The following is a description of a gene set: A kind of anemia in which the volume of the red blood cells is reduced. Microcytic anemia Human Gene Set: HP_MICROCYTIC_ANEMIA studied in species Homo sapiens, and this is the list of marker genes: WAS (WASP actin nucleation promoting factor), PSTPIP1, PIK3CA, HBG1, HBG2, TEK (TEK receptor tyrosine kinase), SLC37A4, IREB2, IL6ST, BCL11A, ATRX, C2orf69, SLC25A10, SLC35C1, SLC25A21, AGGF1, CARD10, TAFAZZIN, LPIN2, SLC29A3, CAT, HBA2 (NCBI Gene Id 3040), HBA1, FECH, KARS1, ALAS2, TRNT1, SUCLA2, HBB, PSMB8, FDX2, TMPRSS6, CP (NCBI Gene Id 1356), TKFC, PUS1, IRX5, WIPF1, RIPK1, OSTM1, SHPK (sedoheptulokinase), KLF1, FARSA, TBK1, DNAJC19, SMPD1, SRD5A3 (NCBI Gene Id 79644, steroid 5 alpha-reductase 3), HBD, HSCB, ABCB7